Given this list of marker genes Pot1a, Msh3, Chtop, Msh2, Ssbp1, Pot1b, Msh6, here is a description of the gene set: species: Mus musculus Mouse Gene Set: GOBP_POSITIVE_REGULATION_OF_HELICASE_ACTIVITY Any process that activates or increases the activity of a helicase.